Given this list of marker genes RGS12, SCAMP2, ITPRIPL1, PRSS33, XPNPEP1, SEZ6L, GYS2, GNA15, COX5B, GAPDH, ACOD1, TOMM40, SPATS2, MLPH, PLA2G2E, GARIN1A, RANBP1, ATP10B, TMEM82, SYNPO, ARHGEF17 (Rho guanine nucleotide exchange factor 17), PLEKHM2, KLRC2, EIF2B5, BEX1, CPNE2 (copine 2), ICAM1, GSTO2, ADCY8, IPO4, DDN, PODNL1, TNFRSF21, CUEDC1, SIX4, H2BC1, CES4A, GNAL, PERP (p53 apoptosis effector related to PMP22), SHC1 (NCBI Gene Id 6464), DLX1, TFG, TNFSF11, PTPN5, PHLDA3, PRR18, KLRC1, CCL4 (C-C motif chemokine ligand 4), SNX9, SPATA7, TTK, BSG (basigin (Ok blood group)), LRRC15, APBA2, GRWD1, PGAM1, PIK3AP1, POLA2, F12, RAD54L, GFAP, DSCC1, THOP1, CXCL3, NHLRC1, PSME2, REG3A, DRD2, SDC4, TSNAXIP1, CCDC68, ASPN, TXNL4B, ZC3H12C, CHAC1, THBS1, RNASE9, CRIP2, THSD1, EGFR, TTC12, CLSTN1, CASZ1, PRDM11, ANKRD13B, BOP1, IL23A, CNTN6, MRPS10, ENO4, DAGLA, NETO1, CDC42BPG, MIR448, PLPP3, PROC, MIF, HPN, CLSPN, UQCRQ, ABCF1, COBLL1, SMYD2, TBC1D8, RRS1, TMEM37, EFTUD2, ECT2, SERPINE2, CCDC159, CAD, CXXC4, SPATS1, PCYOX1L, ADGRG2, SAV1, DUSP15, CHDH, CCDC112, MAGED1, TUBB6, CDC34, MLF1, HCK, TMEM30CP, PLP2, EAF2, GKAP1, TRIM72 (tripartite motif containing 72), PSD, KPNA2, FKRP, PDZK1IP1, ANLN, here is a description of the gene set: species: Homo sapiens Genes down-regulated in control CD4 T cells versus those infected with HIV-1 viruses lacking Env, Vpr and Nef. from publication Dabrowska A, Kim N, Aldovini A (PMID 19050264) Human Gene Set: GSE12963_UNINF_VS_ENV_AND_NEF_AND_VPR_DEFICIENT_HIV1_INF_CD4_TCELL_DN The high mutation rate of HIV is linked to the generation of viruses expressing proteins with altered function whose impact on disease progression is unknown. We investigated the effects of HIV-1 viruses lacking Env, Vpr and Nef on CD4+ T cell gene expression using high-density DNA microarray analysis and functional assays.